The following is a description of a gene set: electronically inferred by orthology from the curated human pathway Reactome Pathway: O2/CO2 exchange in erythrocytes part of: Transport of small molecules species: Mus musculus This event has been computationally inferred from an event that has been demonstrated in another species.<p>The inference is based on the homology mapping from PANTHER. Briefly, reactions for which all involved PhysicalEntities (in input, output and catalyst) have a mapped orthologue/paralogue (for complexes at least 75% of components must have a mapping) are inferred to the other species., and this is the list of marker genes: Cyb5r2, Aqp1, Car4, Slc4a1, Hbb-bt